Given this list of marker genes Akt1s1, Ttbk1, Plk1, Chaer1, Ptpn6, Ereg, Sfrp5, Irak1, Ube2l3, Abi1, Eef1a2, Ube2i, Adrb2, Cenpe, Npm1, Hmgcr, Aplp2, Adarb1, Adcy8 (NCBI Gene Id 11514), Pak1, Agtr1a (angiotensin II receptor, type 1a), Prkcd, Polg2, Sash1, Rpl5, Ins2, Cib1, Rpl11, Erbb2, Cdkn2a, Ajuba, Pkig, Ccnd2, Thy1, Rgs2, Nf1, Xrcc1, Lats2, Lats1, Epm2aip1, Dbi, Rb1, Pdgfb, Gstp2, Chrna7 (NCBI Gene Id 11441), Tnfaip3, Ifng (NCBI Gene Id 15978), Spdya, App, Ang2, Sesn2, Hhex, Adam9, Ptk6, Unc119, Smpd1, Hspb1, Paqr3, Park7, Il3, Il4, Ppm1f (protein phosphatase 1F (PP2C domain containing)), Xrcc6, Dnaja3, Trib2, Tnf, Ptpn22, Pkn1, C1qtnf9, Pik3ca, Bag5, Gas6, Spry2, Rgs14, Prdx3, Dynap, Abl1, Rap1a, Qars1, Uchl1, Cdk12, Tlr4, Dnajc3, Dusp7, Wdr59, Nherf1, Srcin1, Errfi1, Kif14, Ip6k2, Pxn, Hexim2, Sod1, Cdc14b, Higd1a, Ptprj, Ptk2, Cartpt, Ang4, Htr2b, Ang5, Map2k7, Dusp3, Nrg1, Cass4, Gckr (glucokinase regulatory protein), Ang6, Adar, Rfc4, Ptk2b, Ager, Tigar, Prox1, Lrp8, Psen2, Fgf2, Sfrp2, Nprl2, Pkib, Map2k3, Lrrk2, Inpp5k, Zfyve28, Mvp, Pten, Slc8a3, Cln8, Egf, Fgf1, Pdgfrb, D1Pas1, Fgd2, Zfp622, Mre11a, Vangl2, Cdkn1b, Magi3, Ltf, Ect2, Ldb1, Il34, Ccny, Fbn1, Mst1, Mt3, Fbxo7, Rad50, Cdkn2b, Map3k11, Chtf18, Ripk3, Chordc1, Traf2, Apc, Hmgn1, Spatc1l, Mad2l2, Prkn, Mst1r, Fzd4, Ccl19-ps6, Heg1, Traf6, Agtr1b, Nbn, Dscc1, Robo1, Rfc2, Gba1, Ceacam1, Zfp36, Sez6, Nr2f2, Cdc37, Fzd8, Wee2, Pdcd4, Sirt1, Il1b, Gadd45b, Lilrb4b, Ppp2r3c, Mapt, Pik3r5, Sfrp1, Gprc5b, C1galt1c1, Fem1b, Neurl1a, Vegfc, Snca, Men1, Ezh2, Reln, Adam17, Erp29, F2, Limk1, Arhgef5, Ripk1, Fem1a, Fgfr1, Ins1, Stradb, Zgpat, Apoa4, Flt1, Ccnyl1, Ccl19-ps1, Slc8a2, Camk1, Tab1, Prkca, Macroh2a1, Cox11, Ntrk3, Ccnd3, Lilrb4a, Axin1, Slc11a1, Cdk5rap1, Inca1, Stub1, Map2k1, Pnkp, Tead1, Zeb2, Trim27, Synpo2, Map4k2, Lrp6, Vldlr, Lyn, Pum3, Cdc20, Hmga2, Epha4, Cdk5rap3, Rbl2, Ptprt, Ccdc88a, Apoa2, Apoe, Ccn1, Maged1 (NCBI Gene Id 94275), Eif4a2, Chi3l1, Ddx3x (NCBI Gene Id 236681), Vps25, Trib1, Cdkn2c, Dab1, Edn1, Ggnbp2, Lilra5, Spindoc, Cdk5r1, Als2, Usp44, Rtraf, Pih1d1, Tsc2, Gnaq, Tlr6, Prkch, Map3k7, Jak2, Psmd10, Egfr, Pdgfa, Fcer1a, Rapgef2, Strada, Emp2, Ppp1r3f, Rpl23, Cep85, Irs2, Tsg101, Csf1 (colony stimulating factor 1 (macrophage)), Map3k13, Fgd4 (FYVE, RhoGEF and PH domain containing 4), Gstp1, Firrm, Chtf8, Gadd45a, Ccl19-ps4, Edn3, Akt1, Cacul1, Nppa, Nf2, Cdkn1c, Ralb, Tgfb2, Sez6l2, Hras, Mmd2, Shb, Dab2ip, Zfp91, Cdkn2d, Ddr2, Dtx3l, Rps2, Smad7, Taf7, Sez6l, Tinf2, Mrnip, Ppp2ca (protein phosphatase 2 (formerly 2A), catalytic subunit, alpha isoform), Ube2srt (NCBI Gene Id 620508), Insr, Map3k12, Irgm1, Dok7, Cd24a, Notch2, Ksr1 (NCBI Gene Id 51965), Fem1al, Gprc5a, Igtp, Gadd45g, Epo, Cops8, Ern2, Map3k4, Map2k2, Taok3, Btrc, Cav1, Prkag2, Stil, Tlr1, Mastl, Ubash3b, Tnfrsf4, Ppp1r3g, Cd300a, Kitl, Ccl19-ps5, Uvrag, Cimap3, Stk11, Traf4, Cdc25b (cell division cycle 25B), Spry4, Apoa1, Ptpro, Jmjd8, Card10, Ptpn1 (NCBI Gene Id 19246), Abi2, Cblc, Lep, Psen1, Gstp-ps, Jtb, Pik3r6, Midn, Gskip, Dlg1, Ern1, Tnfrsf11a, Rap2b, Ppia, Angpt1, Map2k6, Nek10, Trpt1, Ang, Abi3, Wdr24, Cdk5, Ptprh, Psrc1, Daxx, Rasip1, Spred1, Xrcc5, Arrdc3, Prkrip1, Smg8, Mapre3 (microtubule-associated protein, RP/EB family, member 3), Mtor, Nolc1, Slc1a1, Cd74, Efna1, Agt, Map2k4, Pabpn1 (poly(A) binding protein, nuclear 1, NCBI Gene Id 54358), Cd40, Aida, Dusp19, Iqgap1, Adra2b, Itgb3, Dusp1, Gstp3, Cep43, Snx9, Mmd, Slamf8, Mstn, Nup62, Pdgfc, Pik3cg, Trem2, Bccip (BRCA2 and CDKN1A interacting protein), Cd200, Cd4, Dnaja1, Adipoq, Drd4, Irak3, Epm2a, Epha1, Spry1, Csf1r, Rbl1, Pdcd10, Wnt3a, Map3k10, Ccr7, Cdkn1a, Sptssb, Blvra, Lime1, Cemip, Pde5a, Pycard, Hgs, Syk, Rfc5, Topors, Nox4, Hipk3, Coro1c, Cab39, Stk38 (NCBI Gene Id 77222), Nlrc5, Wars1, Tcl1, Map3k1, Bcl10, Tnfsf11 (NCBI Gene Id 21943), Rap2c, Nrbf2, Dnm1l, Gab1, Wwtr1, Mllt1, Tpx2, Adra2a, Hyal2, Dstyk (dual serine/threonine and tyrosine protein kinase), Ptprc, Rfc3, Mapk8ip3, Pparg, Arrdc4, Tcim, Prkar1a (protein kinase, cAMP dependent regulatory, type I, alpha), Mad2l1, Tspyl2, Bmp2, Bmi1, Spdye4a, Tirap, Asxl2, Tfap4, Syap1, Pcna, Fgf18, Chmp6, Large1, Pkia, Gtpbp4, Grem1, Rhoa, Lmo4, Ptprb, Adra2c, Tsacc, Thbs1, Wnt5a, Hnrnpu, Pim1, Tsc1, Banf1 (NCBI Gene Id 98145), Tab2, Socs4 (suppressor of cytokine signaling 4), Hpf1, Dbndd2, Nrxn1, Rassf2, Wnk4, Sfn, Nedd9, Htt, Phpt1, Map3k5, Irgm2, Gpr39, Stox1, Clspn, Kat2b, Nhlrc1, Dtnbp1, P2rx7, Gsk3a, Mcph1, Ankrd54, Etaa1, Cdk5r2, Agap2, Socs5, Casp3, Ube2s, Rps3 (ribosomal protein S3), Igf1, Slc8a1, Fgr, Fabp4, Sh3bp5, Setd7, Fbxw7, Chrna3, Rasgrp1, Tm9sf5, Trib3, Itgb1bp1, Blm, Dusp10, Agrn, Dusp22, Dynapl1, Rgcc, Ppm1e, Dvl2, Skp1, Ccl19-ps3, Fbxo5, Chp1, Rps7, Smyd3, Tenm1, Ptpn2, Adcyap1, Ccl19 (NCBI Gene Id 24047), Fzr1, Garem1, Deptor, Plec, Kit, Mapk8ip1, Myocd, Tom1l1, Tpd52l1, Ulk4, Cripto, Bag2, Prlr, Src, Pibf1, Ccnd1, Acp4, Fzd5, Ldb2, Ntf3, Ormdl3, Cav3, here is a description of the gene set: studied in species Mus musculus Mouse Gene Set: GOBP_REGULATION_OF_TRANSFERASE_ACTIVITY Any process that modulates the frequency, rate or extent of transferase activity, the catalysis of the transfer of a group, e.g. a methyl group, glycosyl group, acyl group, phosphorus-containing, or other groups, from one compound (generally regarded as the donor) to another compound (generally regarded as the acceptor). Transferase is the systematic name for any enzyme of EC class 2.